Given this list of marker genes ELN, MAP2K2, SF3B2, TMEM270, NBAS, POLR1D, FGFR2, PEPD, KRAS, GTF2IRD2, NECTIN1, RUNX2, MAP2K1, POLR1C, VPS13B, TBL2, SEMA3E, ERI1, FKBP6, POLR1B, OFD1, STX1A, TCOF1, COL11A1, LIMK1, GTF2IRD1, VPS37D, DNAJC30, CHD7, GTF2I, RFC2, EIF4H, TWIST2, CNOT1, METTL27, BAZ1B, NOTCH2, BRAF, BUD23, NCF1, CLIP2, SF3B4, here is a description of the gene set: Underdevelopment of the zygomatic bone. That is, a reduction in size of the zygomatic bone, including the zygomatic process of the temporal bone of the skull, which forms part of the zygomatic arch. Human Gene Set: HP_HYPOPLASIA_OF_THE_ZYGOMATIC_BONE studied in species Homo sapiens Hypoplasia of the zygomatic bone